The following is a description of a gene set: Anchoring fibril formation Human Gene Set: REACTOME_ANCHORING_FIBRIL_FORMATION species: Homo sapiens, and this is the list of marker genes: BMP1, LAMC2, COL7A1, COL4A5, TLL2, LAMB3, COL4A1, COL4A6, TLL1, COL1A2 (NCBI Gene Id 1278), COL1A1, COL4A3, COL4A4, LAMA3, COL4A2